The following is a description of a gene set: This event has been computationally inferred from an event that has been demonstrated in another species.<p>The inference is based on the homology mapping from PANTHER. Briefly, reactions for which all involved PhysicalEntities (in input, output and catalyst) have a mapped orthologue/paralogue (for complexes at least 75% of components must have a mapping) are inferred to the other species. part of: RNA Polymerase II Transcription species: Mus musculus Reactome Pathway: RNA Pol II CTD phosphorylation and interaction with CE electronically inferred by orthology from the curated human pathway, and this is the list of marker genes: Gtf2h2, Polr2c, Rnmt, Polr2i, Gtf2f2, Rngtt, Polr2b, Polr2a, Ccnh, Gtf2f1, Ercc3, Polr2e, Ercc2, Polr2l, Gtf2h4 (NCBI Gene Id 14885), Polr2k, Supt5, Polr2f